The following is a description of a gene set: species: Mus musculus Binding to phosphatidylinositol-3,4-bisphosphate, a derivative of phosphatidylinositol in which the inositol ring is phosphorylated at the 3' and 4' positions. Mouse Gene Set: GOMF_PHOSPHATIDYLINOSITOL_3_4_BISPHOSPHATE_BINDING, and this is the list of marker genes: Kif16b, Sestd1, Adap2, Plekha1, Irgm1, Hip1r, Pla2g4e (NCBI Gene Id 71894), Obscn, Plekha2, Ttpa, Dapp1, Washc2, Fchsd2, Sh3pxd2a, Gab2, Arap3, Plekha4, Myo1g, Mapkap1, Plek2, Rag2, Ncf1, Hip1, Commd1, Zfyve1, Plek, Rs1, Anxa8, Phlda3, Akt1